The following is a description of a gene set: Genes down-regulated in CD4 T cells from healthy donors: resting versus nitric oxide. from publication Fernandez DR, Telarico T, Bonilla E, Li Q, Banerjee S, Middleton FA, Phillips PE, Crow MK, Oess S, Muller-Esterl W, Perl A (PMID 19201859) Human Gene Set: GSE13887_RESTING_VS_NO_TREATED_CD4_TCELL_DN CD3-positive T cells were negatively isolated from 10 SLE patients and 9 healthy controls without SLE. All of the SLE samples and control samples were compared with one another to identify baseline differences in expression due to the disease. Next, T cell preparations from 4 of the control subjects were stimulated with either Nitric Oxide (NOC-18) 600 uM for 24hr or stimulated through CD3/CD28 for 24hr to determine which genes were responsive to these signaling mechanisms. Here, we show that activity of the mammalian target of rapamycin (mTOR), which is a sensor of the mitochondrial transmembrane potential, is increased in SLE T cells. Activation of mTOR was inducible by NO, a key trigger of MHP which in turn enhanced the expression of HRES-1/Rab4, a small GTPase that regulates recycling of surface receptors through early endosomes. Expression of HRES-1/Rab4 was increased in SLE T cells and, in accordance with its dominant impact on the endocytic recycling of CD4, it was inversely correlated with diminished CD4 expression. HRES-1/Rab4 over-expression was also inversely correlated with diminished TCRζ protein levels. Combined with follow up studies, these results suggest that activation of mTOR causes the loss of TCRζ in lupus T cells through HRES-1/Rab4-dependent lysosomal degradation. species: Homo sapiens, and this is the list of marker genes: NKG7, SMYD4, FOLR2, SRBD1 (S1 RNA binding domain 1), PRKG2, KPNA6, DENND6B, PPP1R2, BAG1, LDOC1, CD320, IFNB1 (NCBI Gene Id 3456), RS1 (NCBI Gene Id 6247), CCDC18, TERF2IP, FBXW11, ITGB8 (NCBI Gene Id 3696), CENPF (centromere protein F), GDI1, SLC4A4, PEX3, CRYZL2P, CCDC81, CX3CR1, RPS18, LCN8, PCLO, CRHBP, TCAF1, RGS9, TPM1, FGGY, SH3GL3, GPR160, OTUD6A, FAS, LAT2, TMA7, PDE6A, C1D, FLVCR2, PCDHB6, RAB27B, MIR96, CFAP144P1, SLC41A2, FNDC11, NSMF, OPN3, H3C4, ATL2, CD38 (CD38 molecule), CDKN2AIP, MED21, HMBS (hydroxymethylbilane synthase), ACTA2, COX7B, NPR3, GAS2, GEMIN4, RPL39, KRTAP5-2, GLA, ETFA, ZMAT2, RALBP1, ADGRF2P, IDI1 (NCBI Gene Id 3422), FDFT1, RPL19, ECI2, PLA2G3, NAPB, TMEM14A, SUB1, CCDC73, CD44, MMP12, LYN, SNTG2, BIVM, RPL29, HYLS1, TEX9, KLC2, S100A10 (NCBI Gene Id 6281), SPRY2, TRA2A, MAGEE2, RAB18, RER1, NIPSNAP3A, WDR13, MYH8 (myosin heavy chain 8), SERPINE2 (NCBI Gene Id 5270), CBR4, FHL1, PAX6, GRIK2, SERINC3, RNF25, KYAT1, RGS18, RNF5, TBC1D7, CDKL1 (NCBI Gene Id 8814), F8, IDH1, ARRDC5, POLB, ATP6V1C1, SARNP, CTSD